Given this list of marker genes SPTA1, FGFR2, SPTB, LARS2, SH2B3, SLC4A1, RBM10, HBB, FERMT3, CALR, AKR1D1, ANK1, OSTM1, MPL, CA2, JAK2 (NCBI Gene Id 3717), VPS45, TET2, EPB42, TNFSF11, here is a description of the gene set: The process of hematopoiesis occurring outside of the bone marrow (in the liver, thymus, and spleen) in the postnatal organisms. studied in species Homo sapiens Extramedullary hematopoiesis Human Gene Set: HP_EXTRAMEDULLARY_HEMATOPOIESIS